Given this list of marker genes DRG1, KCNA4, ACAT1, PKLR, PKM (pyruvate kinase M1/2), KCNJ11, PDXK, ATP4A, CPS1, ATP1A1, HDAC4, ATP1A2, ADPRH (NCBI Gene Id 141), here is a description of the gene set: studied in species Homo sapiens Binding to a potassium ion (K+). Human Gene Set: GOMF_POTASSIUM_ION_BINDING